The following is a description of a gene set: Cell stimulation with viral double-stranded (ds) RNA and bacterial lipopolysaccharide (LPS) activate Toll-like receptors 3 (TLR3) and TLR4, respectively, triggering the activation the activation of two IKK-related serine/threonine kinases, TANK-binding kinase 1 (TBK1) and IκB kinase ε (IKKε, IKBKE) which directly phosphorylate interferon regulatory factor 3 (IRF3) and IRF7 promoting their dimerization and translocation into the nucleus. Although both kinases show structural and functional similarities, it seems that TBK1 and IKBKE differ in their regulation of downstream signaling events of TLR3/TLR4. <p>IRF3 activation and interferon β (IFNβ) production by poly(I:C), a synthetic analog of dsRNA, are decreased in TBK1-deficient mouse fibroblasts, whereas normal activation was observed in the IKBKE-deficient fibroblasts. However, in double-deficient mouse fibroblasts, the activation of IRF3 is completely abolished, suggesting a partially redundant functions of TBK1 and IKKε (IKBKE) (Hemmi H et al., 2004). <p>The poly(I:C)-induced phosphorylation of TBK1 and IRF3 was abolished in TRIF (TICAM1)-knockout human keratinocyte HACAT cells (Bakshi S et al., 2017). TICAM1 is utilized as an adaptor protein by TLR3 and TLR4 (Yamamoto M et al., 2003). <p>TLR3 recruits and activates PI3 kinase (PI3K), which activates the downstream kinase, Akt, leading to full phosphorylation and activation of IRF3 (Sarkar SN et al., 2004). When PI3K is not recruited to TLR3 or its activity is blocked, IRF3 is only partially phosphorylated and fails to bind the promoter of the target gene (Sarkar SN et al., 2004). studied in species Homo sapiens Reactome Pathway: TICAM1-dependent activation of IRF3/IRF7 part of: Toll Like Receptor 3 (TLR3) Cascade, and this is the list of marker genes: UBC, TRAF3, RPS27A, IRF3, IRF7, OPTN, TANK, TLR3, UBA52, TICAM1, IKBKE, TBK1, UBB